The following is a description of a gene set: A protein complex facilitating transport of molecules (proteins, small molecules, nucleic acids) into, out of or within a cell, or between cells. Mouse Gene Set: GOCC_TRANSPORTER_COMPLEX studied in species Mus musculus, and this is the list of marker genes: Kcnip4, Kcnmb1, Ano2, Hcn1, Foxred1, Scn8a, Gabra2, Atp6v1e1, Glra2, Fxyd4, Chrna6, Trpv6, Scn9a, Shisa8, Ndufa9, Kcnip2, Chrnb1, Gria4, Atp5pb, Grik2, Pde4d, Cldn17, Clcc1, Catsperb, Ndufb11b, Trpc1, Kcnh3, Grin3b, Kcnk13, Cyc1, Cttn, Glrb, Kcnk4, Eps8, Calm2, Cacng1, Kcnmb3, Kcnh5, Cox8c, Timm8a1, Ndufa6, Tmem30a, Glra4, Ndufa13, Cox6a1, Atp6v1b1, Catsper4, Ndufb8, Dmac1, Chrnb2, Vwc2l, Pex12, Chrnd, Gabrr2, Kcnj12, Best1, Chrna2, Hspa2, Ndufs4, Slc9a1, Kcns2, Dmac2l, Atp6v0a2, Cacna1e, Pex5l, Cacna1a, Kcns3, Cacng6, Ndufa1, Smdt1, Uqcr10, Timm13, Catsper3, Clcnka, Shisa9, Ndufab1-ps, Atp2a2, Ndufaf2, Atp4a, Dlg3, Kcne5, Scnn1b (NCBI Gene Id 20277), Catsperd, Cacna1s, Catsperg2, Gabrg2, Chrna4 (cholinergic receptor, nicotinic, alpha polypeptide 4), Ccdc115, Clcn2, Timm10, Kcne2, Clic5, Abcg5, Catsperg1, Uqcrc2 (NCBI Gene Id 67003), Chrna1, Kcng3, Cox7c, Slc17a8, mt-Atp8 (mitochondrially encoded ATP synthase 8), Ndufs1, Kcnj13, Cacng2, Cngb3, Kcnd3, Gabrr1, Kcnc1, Olfm3, Fxyd2, Atp5mf (NCBI Gene Id 80395), Atp1a2, Kcnip3, Ndufv2, Kcnab1, Cacng5, Ndufv3, Kcnc4, Chrnb3, Ndufb6, Cacna1g, Gabra3, Chrnb4 (cholinergic receptor, nicotinic, beta polypeptide 4), Sumo1, Atp6ap1l, Cacnb2, Slc2a1, Cnga4, Vwc2, mt-Nd5, Ndufb9, Scnn1a, Ndufb4, Catspere2, mt-Co3, Kcns1, Atp6v0e, Amigo1, Clic1, Chrna7, Ndufb1, Ttyh3, Cox8a, Kcna4, Grin2a, Nalcn, Tmem262, Atp5f1d, Atp8b2, Atp5po, Atp6v1h, Uqcrc1 (ubiquinol-cytochrome c reductase core protein 1), Cox6c, Cnga2, Uqcrh-ps1, mt-Nd4, Cox7a2, Scn1a, Grin1, AA467197 (expressed sequence AA467197), Ndufs7, Kcnmb2, Trpm5, Shisa6, Fkbp1a, Kcnq2, Kcng4, Pkd2l1, Hcn3, Ndufa5, Scn5a, Kcnq5, Chrne, Atp5f1c, Gabrb2, Fxyd1, Kcnk1, Ndufb4c, Gabrb1, Micu3, Pkd1, Cox6b1, Gabrb3 (GABRB3, gamma-aminobutyric acid type A receptor subunit beta 3), Uqcc3, Cox6b2, Atp6v1g1, Lrrc8a, Atp6v1g3, Cacna2d2, Hvcn1, Trpc4, Kcnab3, Atp5mc3, Ergic3, Kcnj9, Atp10a, Ndufa12, Kcnmb4, Ndufb11, Stxbp5, Ndufv1, Rnasek (NCBI Gene Id 66944), Kcnq3, Ndufb10, Kcne4, Scn10a, Cngb1 (NCBI Gene Id 333329), Mcu, Kcnj3, Tmem30b, Kcna7, Trpv5, Atp6ap2, Gria2, Slc17a6, Catsper1, Kcnv2, Chrna5, Lrrc26, Ndufa4l2, Ndufab1, Tmem249, Akap6, Efcab9, Cacna1f, Scn1b, Uqcrh, Stx1a (NCBI Gene Id 20907), Grik5, Grid1 (NCBI Gene Id 14803), Atp1b3, Atp1b2, Kcnj10, Kcnh7, Atp11c, Cox8b, Spaar, Ryr2, Cacna2d3, Atp6v1d, Ndufs5, Kcnj16, Gabra1, Calm1, Atp6v0e2, Clic4, Gpr89, Gabrd, Lrrc8d, Glra3, Clcn7, Cox6c2, Trpc3, Cox5b, Uqcrfs1, Ndufb4b, Ptk2b, Kcne3, Pkd2, Atp6v0d2, Catsperz, mt-Atp6, Cftr, Ndufs6, Cox4i2, Tmem199, Kcnq4, Scn4b, Catspere1, Atp1a4, Ndufb7, Sacm1l, Pacc1, Atp5mg, Kcnh1, Gabrq, Vamp2, Dlg2, Cachd1 (cache domain containing 1), mt-Cytb, Cacna2d1, Timm10b, mt-Co2, Ryr1, mt-Nd3, Ndufa7, mt-Nd4l, Atp6v0c, Tpcn1, Ostm1, Ergic2, Atp4b, Cacna1d, Cldn4 (claudin 4), Scn3a, Lrrc8c (NCBI Gene Id 100604), Catsper2, Pex13, Clcn1, mt-Co1, Scn2a, Ndufa11, Chrna9, Atp5pf (ATP synthase peripheral stalk subunit F6), Chrng, Ndufa2, Trpm4, Pln, Ndufs3, Ano1, Trpc6, Lrrc8e, Kcna10, Snap25, Trpc5 (NCBI Gene Id 22067), Kcnip1, Ccdc51, Atp6ap1, Kcna5, Ndufa3, Ano6, Tpcn2, mt-Nd2, Atp10d, Clic6 (NCBI Gene Id 209195), Lrrc52, Cox7b2, Lrrtm4, Lrrc38, Kcnj2, Cox5a, Atp5mc1, Calm3, Cacna2d4, Atp5mk, Scn3b, Ndufb2, Kcnma1, Stac3, Ttyh2, Atp6v0a4, Kcnc2, Kcnj1, Scnn1g, Pkd1l1, Grik4, Micu2, Gabrg1, Atp6-ps, Ndufa10, Gabra6, Abcg8, Gabra4 (NCBI Gene Id 14397), Atp6v1c1 (NCBI Gene Id 98003), Scn4a, Atp6v0a1, Ryr3, Kcnd1, Grid2 (glutamate receptor, ionotropic, delta 2), Atp5pd (ATP synthase peripheral stalk subunit d), Cacnb4, Mcub, Atp1b1, Kcne1, Ttyh1, Atp5f1e, Pex14, Uqcrb, Kcnab2, Olfm2, Abcc9, Atp1b4, Abhd12, Ndufb5, Gria1, Unc80, Tcirg1, Grin2c, Kcnb1, Chrna10, Atp8b4, Kcnv1, Cacng4, Atp6v1b2, Atp1a1, Dlg4, C2cd6, Atp6v1f, Dpp10, Chp1, Cacng8, Lrrc8b, Porcn, mt-Nd1 (NCBI Gene Id 78300), Atp10b, Kcng1, Trpc2, Atp5mc2, Kcnk2, Abcc8, Atp11a, Ndufa11b, Cacna1i, Kcng2, Shisa7, Slc17a7, Tmem37, Gabrp, Atp5f1a, Kcnb2, Kcna2, Clic3, Kcnq1, Kcna6, Cacng3, Kcnc3, Kcnj4, Atp1a3, Glra1, Atp8a2, Cnga3, Cacng7, Kcnd2, Scn2b, Kcnf1, Dpp6, Mfsd8, Kcnk7, Cox7b, Ndufa8, Uqcrq, Best3 (bestrophin 3), Cntnap2, Cox7a2l, Clcnkb, Ndufs2, Gabra5 (gamma-aminobutyric acid type A receptor subunit alpha 5), Best2, Kcna3 (NCBI Gene Id 269476), Cacna1h, Cacna1c, Kcnj6, Grin2b, Gria3, Kcnj14, mt-Nd6, Slc26a6, Cpt1c, Htr3a, Akap9, Fkbp1b, Chrna3, Cox4i1, Atp6v1c2, Pkd1l3, Trdn, Atp8b1, Ndufs8, Timm9, Kcnj11, Atp6v1g2, Kcnj5, Htr3b, Cox7a1, Cacnb1, Atp5f1b, Lrrc55, Ndufc1, Slc5a3, Cybb, Trpc7 (NCBI Gene Id 26946), Wdr93, Atp5mj, Grin2d, Grin3a, Hcn4, Olfm1, Kcnh2, Scn11a, Tmem109, Ndufb3, Cacna1b, Uqcr11, Atp5me, Dmac2, Ndufs6b, Atp6v1a, Atp6v0b, Atg5lrt, Grik3, Sestd1, Grik1, Hcn2, S100a9, Cnih2, Cox6a2, Ndufa4, Kcnu1, Kcnh8, Abhd6, Kcnj8, Micu1, Nrn1, Cnga1, Ndufc2, Kcnj15, Atp11b, Atp8a1, Kcna1, Gabrg3, Cacnb3, Ptpa, Abcb8 (NCBI Gene Id 74610), Lrg1, Cnih3, Slco6c1, Atp6v0d1